Given this list of marker genes Dynll1, Epcip, Kif5b, Dnm1l, Myo19, Pkd1, Tspan9, Tspan4 (NCBI Gene Id 64540), here is a description of the gene set: studied in species Mus musculus A cell migration-dependent mechanism for releasing cellular contents. Mouse Gene Set: GOBP_MIGRACYTOSIS